Given this list of marker genes HLA-DRA, PCBP2, RPL34, NRN1, KLF2, HLA-E, PDLIM1, CRIP2, RPL29 (ribosomal protein L29), ADAM15, CD74, APLNR (NCBI Gene Id 187), TMSB10, FLOT1, RPS11, LYST, RPS21, HLA-DPB1, WNK1, RPS24, RPS12, RPL7A, IFITM2, SOX18, ACTN1, RPL11, SAT1, AQP1, PSME2, HSPB1, RBIS, CD93, MYL12A, PIM3, MYH9, RPS6, YBX1, DUSP23, RPL37, SYNE2, FKBP1A, PLAT, VAMP3, CAVIN1, CLU, GIMAP6, RPL36, PTPRB, NPDC1, PLK2, LRRFIP1, EEF1A1, PLVAP, ACKR1, RPL3, RPS18, CAST, LIFR, PLSCR1, NAA38, MGST2, GIMAP1, S100A10, CLEC2B (NCBI Gene Id 9976), IFITM3, CRHBP, HLA-DMA, ZFYVE21, NPC2, SOCS3, SDCBP, CRIM1, RPS8, HMGB2, POLE4 (NCBI Gene Id 56655), ANXA4, OCIAD2, CLTA, CCL14, IL33, RPL15, SUN1, TSPAN7, RPL35A, TPM3, ID1, RPL17, YBX3, GIMAP5, BCAM, NOP10 (NCBI Gene Id 55505), S1PR1, RPS3A, RPL31, NDRG1, JAM2, RPL32, MARCKSL1, GNAQ, RPS28, ADIRF, HLA-DRB1, SNHG7, CAPZA2, MAP1LC3B, GNG5, IFITM1 (interferon induced transmembrane protein 1), IL6ST, RPS15A, NSRP1, PKP4 (NCBI Gene Id 8502), SPARCL1, GNG11, NFKBIA (NFKB inhibitor alpha), RPS23, HLA-DPA1, ID3, RPL8, SLC2A3, SMAD1, RAB11A, TM4SF18, ERG, RPL7, LMCD1, IL3RA, CALCRL, ETS2, KCTD12, HLA-DQB1, FXYD5, EGFL7, MTUS1, RPS5, GIMAP7, RPS4Y1, RPL10, IGFBP4, RPS9, SNRPF, ZFAS1, FOXP1, RAMP3, NUAK1, ECSCR, CYYR1, ZFP36L2, COMMD6, IFI16, ADGRL4, FABP5, CTSC, HYAL2, HLA-DQA1, RPLP0, TGFBR2, SNHG8, RPS6KA2, BHLHE40, RPS14, JCAD, HLA-B, ARL4A, PERP, TPT1, NOSTRIN, GUK1, HINT1, TSHZ2, KLF4, RPS25, LIMS1, RPS13, UBXN1, NAP1L1, GADD45B, YWHAE, CCNI, RPL12, PFDN5, PALMD, SET, SH3BP5, TPM4, MMRN2, DOCK9, ATP5MC2, S100A16, PTMA, GNAI2, HLA-A, FLI1, CYSTM1, RPL22, RPS2 (NCBI Gene Id 6187), GIMAP4, NEDD9, SNCG, CHMP3, RPS4X, GBP4, PRMT1, CD59, MAP3K11, RPS7, RPS27A, ITM2A, TM4SF1, HSPD1, PRCP, LDB2, RPL36A, TMSB4X, ELK3, RPL26, CRTAP, LY6E, RPS15, RPS19, TMEM273, AKR1C3, EIF4B, ABLIM1, ARL6IP1, EGLN1, here is a description of the gene set: Human Gene Set: RUBENSTEIN_SKELETAL_MUSCLE_PCV_ENDOTHELIAL_CELLS from publication Rubenstein AB, Smith GR, Raue U, Begue G, Minchev K, Ruf-Zamojski F, Nair VD, Wang X, Zhou L, Zaslavsky E, Trappe TA, Trappe S, Sealfon SC (PMID 31937892) studied in species Homo sapiens